The following is a description of a gene set: studied in species Mus musculus Mouse Gene Set: MIR_130A_5P from publication Chen Y, Wang X (PMID 31504780) Genes predicted to be targets of miRBase v22 microRNA mmu_miR_130a_5p in miRDB v6.0 with MirTarget v4 prediction scores > 80 (high confidence targets)., and this is the list of marker genes: Itpripl2, Tbc1d8b, Cd80, Pcdha2, Slc26a5, Dennd2a, Rala, Raly, Rora, Piga, Gabra1, Slc24a2, Mettl14, Sh3d19, Cd2ap, Phf14, Pphln1, Pter, Pcdh15, Wscd2, Kdm7a, Pcdha7, Cfl2, Rbfox2, Synj2bp, Mstn, Pdcd6ip, Mgat4c, Trib3, Fxr2, Plppr5 (NCBI Gene Id 75769), Itga8, Sipa1l2, Cntrob, Acot8, Nova1, Eif4h, Dcdc2a (doublecortin domain containing 2a), Dmbx1, Scn9a, Cd226, Dlg2, Rab3b, Rpn2, Nhlrc2, Epha5, C1rl (NCBI Gene Id 232371), Olfm3, Map3k2, Arv1, Cdk2, Myo1b, Exph5, Bub3, Bud23, Hpcal4, Adgrl2, Klhl42, Npas3, Ddhd1, Cpeb4, Mapk9, Fut9, Zfp575, Camk1d, Asxl2, Fgf8, Vsig10, Slk, Bnc2, Megf9, Lzts3, Cdon (cell adhesion molecule-related/down-regulated by oncogenes), Pip5k1b, Bola1, Cdh10, Cyp20a1, Cnot9, Col25a1, Cwh43, Zfp704, Vcpip1, Pcdha12, Clcf1, Hmgcs2, Setd3, Med13l, Gfpt1, Olig3, Il11ra3, Pcdha6, Pcdha5, Malrd1, Crls1, Dio2, Runx1t1, Il11ra1, Trim45, Sgms1, Pcdha8, Pappa2, Phactr2, Or51ab3, Myot, Kctd6, Med13, Mafg, Tigd4 (tigger transposable element derived 4), Lpp, Des, Lrrc58, Msi2, Brwd3, Egln3, Otop1, Ablim1, Ppip5k2, Apbb2, Zfp28, Plp1 (NCBI Gene Id 18823), Hhip, Brinp1, Runx1, Zfp362, Cep43, Tmem209, Hoxa5 (homeobox A5), Tmem165, Grm4, Slc39a14 (solute carrier family 39 (zinc transporter), member 14), Sanbr (NCBI Gene Id 71675), Hoxa9, Zfp710, Gm5460, Pcdha1, Tnfrsf11b, Dscam, Slc25a21, Chl1, Chrdl1, Kcnc2, Slc38a9 (solute carrier family 38, member 9), Foxp1, Ccne2, Morc2a, Naa50, Slc34a1, Lats1, Galnt13, Nrn1, Pcdha3, Prorsd1, Slc39a8, Clock (clock circadian regulator), Grpel2, Angptl8, Trabd2b (TraB domain containing 2B), Sgms2, Hnf4g, Mfsd4b5, Defb1, Spp1, Timm17a, Ccdc87, Cdin1, Shtn1, Tgfa, Cpeb2, Cyp3a41a, Fbxo11, Lonrf3, Magi1, Tmem202, Ptpre, Msl1, Zfp36l1, Twist1, Trio, Jag1, Zmynd11, Cpped1, Hoxb3 (homeobox B3), Ccdc22, Baiap2l1, Hemgn, Cnr1, Pcdha9, Pcdha10 (NCBI Gene Id 12943), Zc3h12a, Pcdhac1, Hoxd8, Pcdhac2, Zscan29, Fyn, Cyp3a11, Nmrk1, Med14, Cadm2, Mef2c, Chmp7 (charged multivesicular body protein 7), Arid3a, Mef2a, Pde1c, Pkib, Cask, Cisd2, Dip2c, Fsbp, Cyp3a41b, Rsf1, Tmem47 (NCBI Gene Id 76833), Oprk1, Rab30, AI593442, Mbnl3, Cyp2ab1, Kcnn3, Gpd2, Cpeb3, Myorg, Dtna, Sp1, Serpinf1, Pakap, Pcdha11, Pcdha4, Hoxc6, Gng2, Gucy1a2, Mbnl1, Cep97, Chic1, Hivep2, Arvcf, Rest, Tead1, Lhx9, Peak1, Pdzd2, Nrxn1, Pkp4, Pcdh20, Papolg, Adam10, Tgfbr3, Mdp1, Ddx6, Snhg11, Rbm18, Slc4a11, Abcd2